The following is a description of a gene set: To analyze gene expression in in regulatory T cell precursors that develop in the absence of a functional Foxp3 protein as compared to that of normal regulatory T cells from publication Lin W, Haribhai D, Relland LM, Truong N, Carlson MR, Williams CB, Chatila TA (PMID 17273171) studied in species Homo sapiens Genes down-regulated in T conv versus T reg. Human Gene Set: GSE6875_TCONV_VS_TREG_DN, and this is the list of marker genes: LAMA5, MRPL4, DICER1, TLR8, WDR3, ACSBG2, TUB, SMC4, FOXB2 (forkhead box B2), INO80B, RBM6, TAL2, BRI3BP, DIP2C (disco interacting protein 2 homolog C), WIZ, PUDP, ADARB1, EIF4EBP1, CLIC4, PRKAR1B (protein kinase cAMP-dependent type I regulatory subunit beta), CST8, CBX2, MRPL20-AS1, CBR3, PALM, CUEDC2, PI4K2A, LIN7B, RIN2, IFI30, ISLR2, HEYL, TRAM2, SBSPON, SLC39A12, CORO6, DENND2A, CREG2, WDPCP, ASPDH, CHAD, FTL, WNT5B, TTC34, CILP, LDHA, CDCA7L, WDR46, PPP1R14D, FXYD6, IFI27L2, MED16, NAGS, TOPBP1, IL22RA2, PXYLP1, MPO, ATP5MK, UQCR10, RHAG, RRP9, SUMO3, LDB2 (NCBI Gene Id 9079), NYAP1, B4GALT1, NOVA1, GNG3, ZCCHC13, NAT14, CCT5, GOT2, EXOSC5, OLAH, KLF1, SSPN, PSAP, SLC4A4, ZNRD2, LRCH2, ACKR3, FMNL1, MAB21L2, PLEC, SLC25A38, HAUS1, ACAD8, DNAI1, PLIN3, DDX49, MLLT3 (NCBI Gene Id 4300), NPHS2, LIN28A, TNFSF11, NKX6-1, ATAD3A, UQCR11, HOXA10, TBX20, FKBP4, ATIC, NCS1, ST6GALNAC2, CENPU, RUVBL1, ELAPOR1, CDC25A, FBXO17, CFAP69, AKAP1, KANK3, TUBA8, BCORL1, PTPN1, HEBP2, ITPRIPL1, PLXNA1, RPS6KL1, GP5, ORM1, ABI2 (abl interactor 2), GTF2F1, RBFA, SPTSSB, C1orf53, LEAP2, SLC7A14, PPEF2, PSD3, AP4M1, UNC5C, AMTN, EIF3L, PON1, CCNE2, MRPL42, DSTN, PLA2G2E, FKBP11, VIPR2, SLC25A6, TTLL7, KRT76, SALL4, CXADR, DGCR8, MZT2B, NPDC1, CNPY1, LIF, NCBP2AS2, KIAA1549L, S100A10, MTFP1, POLR2I, CEP19, ACADL, PEPD, SYT1, PRR15, FGFR4, CAPG, TP73, ACSL1, ADAMTSL5, UPK1A, NFIC, SEL1L3, SNTB2, GHR, TIGD3, ETFB, TNP1, TIMP4, TIMM44, RNASEH2A, HIVEP3, GLI3, RNF207, ALAD, SOX5 (SRY-box transcription factor 5), PLA2G10, CLEC4M, CREB5, SHC3, ACTR3B, ZBTB7B, CLHC1, ATP13A5, LSM4, MRPL45, IQCH, TNNT2, MRPL58, KLHL40, SNCB (NCBI Gene Id 6620), KCNN3 (potassium calcium-activated channel subfamily N member 3), CCNF, HNRNPA3, POLQ